The following is a description of a gene set: Human Gene Set: GOBP_NEGATIVE_REGULATION_OF_GLYCOGEN_METABOLIC_PROCESS species: Homo sapiens Any process that stops, prevents, or reduces the frequency, rate or extent of the chemical reactions and pathways involving glycogen., and this is the list of marker genes: ENPP1, INS (NCBI Gene Id 3630), PPP1R3B, GSK3A, INPP5K, SELENOS, MIR15B, PRKAG3, GSK3B, MIR1271, MIR195, PASK (PAS domain containing serine/threonine kinase), GRB10